The following is a description of a gene set: Mouse Gene Set: GOBP_POSITIVE_REGULATION_OF_OXIDOREDUCTASE_ACTIVITY species: Mus musculus Any process that activates or increases the frequency, rate or extent of oxidoreductase activity, the catalysis of an oxidation-reduction (redox) reaction, a reversible chemical reaction in which the oxidation state of an atom or atoms within a molecule is altered., and this is the list of marker genes: Ifng, Edn1 (endothelin 1), Fcer2a, Akt1, Esr1, Cdh3, Abl2, Ndufa4, Htr2b, Ccs, Snca, Abl1, Cox17, Edn2, Gdnf, Terf2, Sirt3, Tnf, Gch1, Lgals9, Por, Scarb1, Nus1, Ripk3, Rfk, Atp7a, Tert, Coa8, Fxn, Fgf23, Dhfr, Park7, Vdr, Sdhaf4, Ftmt, Cyp27b1, Il1b, S100a1